Given this list of marker genes MAFA, MEN1, CDKN1A, VHL, CDKN2B, CDKN1B, KCNJ11, CDKN2C, CCND1, here is a description of the gene set: Pancreatic islet cell adenoma Human Gene Set: HP_PANCREATIC_ISLET_CELL_ADENOMA The presence of an adenoma of the pancreas with origin in a pancreatic B cell. species: Homo sapiens